Given this list of marker genes ELK1, PRKCA, PRKCG, PRKCB, PLCG2, TGFA, PLCG1, EGFR, here is a description of the gene set: TGFA-EGFR-PLCG-PKC signaling pathway. Pathway ID: N00227. Pathway type: Reference. Pathway class: nt06263 Hepatocellular carcinoma. Pathway Definition from KEGG: TGFA -> EGFR -> PLCG -> IP3 -> (Ca2+,DAG) -> PKC -> ELK1 Human Gene Set: KEGG_MEDICUS_REFERENCE_TGFA_EGFR_PLCG_PKC_SIGNALING_PATHWAY studied in species Homo sapiens